The following is a description of a gene set: The process whose specific outcome is the progression of the forebrain over time, from its formation to the mature structure. The forebrain is the anterior of the three primary divisions of the developing chordate brain or the corresponding part of the adult brain (in vertebrates, includes especially the cerebral hemispheres, the thalamus, and the hypothalamus and especially in higher vertebrates is the main control center for sensory and associative information processing, visceral functions, and voluntary motor functions). Mouse Gene Set: GOBP_FOREBRAIN_DEVELOPMENT species: Mus musculus, and this is the list of marker genes: Emx2, Rhoa, Dbi, Mme, Setd2, Pax4 (NCBI Gene Id 18506), Atp2b4 (ATPase, Ca++ transporting, plasma membrane 4), Creb1, Mfsd2a, Nog, Aqp1, Lpar1, Crkl, Lhx1, Tubb2b, Cdk5, Plcb1, Avpr1a, Kcna1, Pcnt, Hhex, Rbpj, D130043K22Rik, Coro1c, Ext1, Tmem108, Ubb, Ghrh, Myh10, Sema7a, Dmxl2, Pex13, Nr2e1, Atp1a3, Crtac1, Crk, Tyrobp, App, Rac3, Fezf2, Numbl, Atp1a2, Ogdh, Large1, Atic, Dync2h1, Zfp335, Cntn2, Secisbp2, Tacc1, Ngf, Fezf1, Bmerb1, Wnt7a, Apaf1, Slc4a10, Aldh1a3, Afdn, Rnf7, Six3, Filip1, Wnt2b, Drd2, Zeb2, Kif14, Wdr47, Uncx, Zswim6, Ptger3, Igf2bp1, Prkg1, Cdon, Sox2, Sox3, Kat2a, Robo2, Pex5, Kif26a, Pitx2, Rtn4r, Psen1, Ski, Tacc3, Wnt4, Ghrhr, Nr4a3, Atg16l1, Pfdn1, Kdm6b, Cul5, Epha5 (NCBI Gene Id 13839), Csf1r, Shank3, Lypd6, Bcan, Mettl3, Mas1, Kcnc1, Otx1, Nfib, Sstr1, Dock7, Nrp1, Nrg3, Stil, Kdm2b, Fbxo41, Bbs2 (NCBI Gene Id 67378), Prop1, Mir141, Htra2, Htr5a, Duox2, Gli2, Plxna3, Pitx1, Fos, H2ax, Gdf7 (NCBI Gene Id 238057), Pax6, Sox1, Pcm1, Pten, Nr4a2, Nr2f1, Zic3, Tox, Tnr, Dpcd, Fyn, Vax2, Prox1, Mdga1, Kif3a, Rrm1, Ncor2, Ccdc85c, Nr2f2, Pou3f2, Numb, Hspa8, Vps13b, Usp9x (ubiquitin specific peptidase 9, X chromosome), Pou1f1, P2ry12 (purinergic receptor P2Y, G-protein coupled 12), Shh, Slitrk5, Bmpr1a (NCBI Gene Id 68748), Lhx2, Hdac2, Ccdc141 (coiled-coil domain containing 141), Lhx5, Btbd3, Efhc1, Btg2, Wnt5a, Slc38a2, Atoh1, Chrd, Tfap2c, Mir9-3, Rpgrip1l, Zbtb18, Tal2, Mir376a, Rtn4, Plxna4, Pianp, Disc1, Mrtfa, Lef1, Uqcrq, Pgap1, Kirrel3, Fabp7, Gnaq, Ascl1, Axl, Htt, Kdm1a, Col3a1, Notch1, Notch3, Erbb4, Tbx19, Nrp2, Foxb1, Ccdc39, Kif21b, Efna2, Tcf7l2, Chrnb2, Kcna2 (potassium voltage-gated channel, shaker-related subfamily, member 2), Gli3, Gart, Atf5, E2f1, Pak1, B2m (beta-2 microglobulin), Nkx2-1, Bax, Prdm8, Neurod1, Top2b, Kif1a, Slc6a3, Arl13b, Fbxo45, Lamb1, Adgrg1, Zdhhc16, Trappc9, Rac1, Sun2, Pou4f1, Fut10, Hif1a, Draxin, Abcc1, Sin3a, Prdm13, Mettl14, Uba6, Sema3e, Otx2, Rab3gap1, Dct, Lmx1a, Ezh2, Hap1, Ift88, Cdk5r2, Ophn1, Lrrk2 (leucine-rich repeat kinase 2), Ryk, Ntrk2, Sun1, Bbs1, Wdr62, Alk, Src, Id4, Fgf13, Elavl4, D16Ertd472e, Rtn4rl1, Syne2, Casp3, Srf, Sct, Th (tyrosine hydroxylase), Tuba1a, Nfix, Rara, Slc1a2, Foxg1, Ncam1, Mecp2, Tyro3, Slit1, Arx, Tsc1, Lhx3, Mir429, Fut1, Uchl5, Cntnap2, Dlx5, Csnk2a1, Msx1, Zic1, Hes1, Pou3f3, Sall1, Neurog3, Mkks, Szt2, Gli1, Id2, Rarb, Sall3, Grin1, Gria1, Mir9-1, Egfr, Xrcc1, Ephb3, Tra2b, Dmd, H2aj, Ptchd1, Pomt2, Ulk4, Chd5, Dnah5, Fgfr3, Otp, Slc7a11, Dmrta2, Kcnq2, Ephb2, Akirin2, Gak, Gbx2, Zeb1, Dicer1, Tubb2a, Sstr3, Sema5a, Twsg1, Gsc, Psen2 (NCBI Gene Id 98295), Gsx2, Frs2, Lrp8, Tfap2a, Sstr2, Lrp6, Ywhae, Robo1, Atp1b2 (ATPase, Na+/K+ transporting, beta 2 polypeptide), Kcna3, Pax5, Herc1, Fgf2, Fgfr1, Pou3f4, Hmga2, Nde1, Socs7, Hnrnpk, Avpr2 (arginine vasopressin receptor 2), Bhlhe22, Kcnc2, Ptprs, Fgf10, Nkx2-6, Ttc8, Npy, Wnt1, Arhgap35, Wdr89, Aplp1, Slit2, Nin, Fgfr2, Wnt7b, Bloc1s6, Oxtr, Olig2, Slc32a1, Rfx4, Smarca4, Fez1, Hes5, Dab2ip, Pou3f1, Gmppa, Atp7a, Gdpd5, Dab1, Cxcl12, Smo, Mapk8ip3, Dlc1, Scn2a, Aplp2, Crh, Dkk1, Fxr2, Mrtfb, Foxp2, Dixdc1, Srd5a2, Bmp2, Grcc10, Wdr37, Emx1, Atg7, Mir9-2, Rapgef2, Fat4, Bnip3, Mir200b, Agtpbp1, Ndst1, Rax, Lhx8, Neurog1, Eif2b5, Mir200c, Xrn2, Dclk1, Bmp4, Mecom, Cdh2, Dclk2, Nf1, Hesx1, Cep120, Dcx, Nf2, Dlx1, Cdk5r1, Cnp, Ttbk2, Isl1, Anxa3, Tsku, Ctnnb1, Hprt1, Atat1, Mir200a, Pomgnt1, Neurod6, Rtn4rl2, Arid1a (AT-rich interaction domain 1A), Hdac1, Ikzf1, Atrx, Pafah1b1, Ncor1, Inhbb, Trp73, Ndnf, Adcyap1, Fktn, Ppp1r9b, Wnt3a, Tacc2, Aspm, Tctn1, Fgf8 (fibroblast growth factor 8), Zmiz1, Ttc21b, Smarcc2, Cxcr4, Tbr1, Scyl2, Gata2, Neurog2, Htr6, Celf1, Mdk, Bcl11b, Zic5 (NCBI Gene Id 80626), Sema6b (sema domain, transmembrane domain (TM), and cytoplasmic domain, (semaphorin) 6B), Ndel1, Inhba, Mgarp, Itgam, Plxna1, Tbx3, Sec1, Nhlh2, Pcsk1, Flna, Phactr1, Gsx1, Sema3a, Aldh1a2, Nsun5, Drd1 (NCBI Gene Id 77537), Kras, Chd7, Nefl, Reln, Pals1, Ncoa1, Nrg1, Akna, Gsk3b, Mcph1, Nars1, Lhx6, Lrp2, Hook3, Dlx2, Slc2a1, Bbs4, Srgap2, Mboat7, Fxr1, Cckar, Eomes